Given this list of marker genes NEDD8, UBA52, URM1, UBL5, FAU, ATG12, SUMO1P1, SUMO3, ISG15, RPS27A, SUMO4, SUMO2, SUMO1, UBB, UBC, here is a description of the gene set: A molecular function exhibited by a protein that is covalently attached (AKA tagged or conjugated) to another molecule (for example a protein or a lipid) where it acts as a marker, recognized by the cellular apparatus to target the tagged protein for some cellular process such as modification, sequestration, transport or degradation. species: Homo sapiens Human Gene Set: GOMF_MOLECULAR_TAG_ACTIVITY